Given this list of marker genes PAH, KIF7, DVL1, PPP2R3C, CANT1, here is a description of the gene set: Bifid distal phalanx of the thumb studied in species Homo sapiens Human Gene Set: HP_BIFID_DISTAL_PHALANX_OF_THE_THUMB Partial duplication of the distal phalanx of the thumb. Depending on the severity, the appearance on x-ray can vary from a notched phalanx (the duplicated bone is almost completely fused with the phalanx) to a partially fused appearance of the two bones.